The following is a description of a gene set: studied in species Homo sapiens Any process that modulates the frequency, rate or extent of muscle adaptation. Human Gene Set: GOBP_REGULATION_OF_MUSCLE_ADAPTATION, and this is the list of marker genes: GSK3A, MIR25, CAV3, MIR34B, LMCD1, ADCY10, MYMK, TRPC3, MIR208A, SCN5A, TNFRSF1A, MEF2A, NR4A3, NOL3, HDAC4, PPP3CA, TRIM63, P2RX4, PRKCA, G6PD, FOXO3, PDE9A, PPARA, CAMK2G, LMNA, PPARG, MIR1-1, CAMK2B, PARP2, GLRX3, ACACB, ADRA1A (NCBI Gene Id 148), KLF4, CAMK2D, STUB1, RGS2 (regulator of G protein signaling 2), MIR19B1, IGFBP5 (NCBI Gene Id 3488), ERRFI1, BECN1, EDN1 (NCBI Gene Id 1906), MIR19A, PI16, TNNC1, ACTN3, MIR208B (microRNA 208b), SMAD4, BMP10, MIR199B, GTF2IRD1 (NCBI Gene Id 9569), MIR145, DAG1, MIR499A, PRKAG3, MYOG, FOXO1, CERS1, TNNT1, APLNR, NOS3, MTPN, MLIP, MIR133A1, IL6ST, IGF1, NOTCH1, TWF1, MIR21, ATP2A2, ARRB2, MIR214, SELENON, TOMM70, ROCK2 (Rho associated coiled-coil containing protein kinase 2), TNNI1, FOXP1, GATA5, HAND2, MIR17HG, MIR20A, MIR34C, PAK1, AKAP6, AGT, RGS4, CTDP1, SMAD3, ARRB1, PARP1, CASQ1, YY1 (NCBI Gene Id 7528), SLC9A1 (solute carrier family 9 member A1), ROCK1, TNFRSF1B, MIR17, MIR199A1, FBXO32, ATP2B4, MYH7